The following is a description of a gene set: studied in species Homo sapiens Genes up-regulated in CD4 Th1 cells: control versus anergic. from publication Zheng Y, Zha Y, Spaapen RM, Mathew R, Barr K, Bendelac A, Gajewski TF (PMID 23548837) Human Gene Set: GSE46242_TH1_VS_ANERGIC_TH1_CD4_TCELL_UP T cell anergy is one of the mechanisms contributing to peripheral tolerance, particularly in the context of progressively growing tumors and in tolerogenic treatments promoting allograft acceptance. We recently reported that early growth response gene 2 (Egr2) is a critical transcription factor for the induction of anergy in vitro and in vivo, which was identified based on its ability to regulate the expression of inhibitory signaling molecules diacylglycerol kinase (DGK)-a and -z. We reasoned that other transcriptional targets of Egr2 might encode additional factors important for T cell anergy and immune regulation. Thus, we conducted two sets of genome-wide screens: gene expression profiling of wild type versus Egr2-deleted T cells treated under anergizing conditions, and a ChIP-Seq analysis to identify genes that bind Egr2 in anergic cells. Merging of these data sets revealed 49 targets that are directly regulated by Egr2. Among these are inhibitory signaling molecules previously reported to contribute to T cell anergy, but unexpectedly, also cell surface molecules and secreted factors, including lymphocyte-activation gene 3 (Lag3), Class-I-MHC-restricted T cell associated molecule (Crtam), Semaphorin 7A (Sema7A), and chemokine CCL1. These observations suggest that anergic T cells might not simply be functionally inert, and may have additional functional properties oriented towards other cellular components of the immune system., and this is the list of marker genes: PTPRN2-AS1, YIPF2, STAC3, CCDC125, ZMYND11, RFPL2, TSPAN14, HSD17B14, C1orf53, ARIH2OS, GIMAP4, GALM, G6PC3, CCDC9B, PFKFB4, CD1D, TRMT112, SIL1, POLH, SSTR1, IL2RA, TBL2, BBS5, LIN28B, TBXAS1, PLAT, NYAP2, ENTPD1, SETD3, NSUN5P2, PLA2G5, TEDC2, HIVEP2, PRKCB, IPP, CX3CL1, SSR2, GUSB, SLC2A9, TOP1, USP4, FBP1, ACVRL1, MYADM, CFAP184, STAG3, LIMK2 (NCBI Gene Id 3985), RASIP1, GPS2, TGM2, STX18, TRIM31, ST7-OT4, UPP1, MYL6B (NCBI Gene Id 140465), GP9, RAB20, C1orf122, POLR1H, BRAP, CIMIP1, IP6K1, C2CD3 (C2 domain containing 3 centriole elongation regulator), LINC00630, CD300LF, ACOT8, LRRC32, SUPT4H1, SNORA21, TP53TG1, ZNF713, POMP, ANKHD1, EMX1, DPM2, NUP210, PCK2, ATP6V0E2, TP53RK, UXT, PGPEP1, FHIT, AMPD2, PLPP2, LFNG, CR1, CDCA4, KRTAP10-12, PHC1, CECR3, UBTD1, CD300A, EHD4, TGIF2, HCST, MATK, SLC45A3, TRAPPC14, FLT1 (fms related receptor tyrosine kinase 1), STK38, VNN2, DHX8, NKG7, SRGN, PRKCE, ITPRIPL2, SUOX, CDK5, UCK2, GYPB, FARSA, COA3, PPFIA4, RCSD1, AGO1, NYX, FN1, CXCL16, XYLT1, RGCC, DPH2, LBR, WFS1, BCL2L10, RNF41, HSBP1, PLBD1, CHCHD4, SIGLEC7, INO80D, CES2, MTMR14 (myotubularin related protein 14, NCBI Gene Id 64419), C8orf88, SIGLEC15, ITGAE, NEDD8, ENSG00000249695, ITGB3, ARL8A, TMUB1, MT1HL1, ZSCAN16, ALOX5AP, TFCP2L1, SIPA1, LY9, ADGRL1, CLEC2L, DACH1, EIF1B, TNC, SLIRP, TUB, SERPINB6, ACTR3C, RHBDF2, PGBD5, HSD11B2, FASTKD1, FGR, HARS1, CREB3L2, ENG, GNL3L, TWF2, SERF2, STPG4, PTGS1, CARD14, DCAF12, MLX, EEPD1, BACE1, NPC2, PMS2P5 (PMS1 homolog 2, mismatch repair system component pseudogene 5), MSL2, TMEM177, SIGLEC17P, LINC00900, SEL1L3, HPCAL1, RAB25, PTBP1, PTPRU, NDUFA2, ZNF283, ALG10B, NME6, HDAC8, PLPP3, MAFK, ALKBH3, NRIP3, NEK6, PLCB2, NPLOC4, CES3